Given this list of marker genes PCYT1A, LIPA, FOCAD, AHCY, PCK1, SLC37A4, MPV17, PIGA, STAT3, here is a description of the gene set: studied in species Homo sapiens Abnormal liver sonography Human Gene Set: HP_ABNORMAL_LIVER_SONOGRAPHY An abnormal appearance of the liver or any of its components on sonography (ultrasound).